The following is a description of a gene set: A large lipoprotein particle (diameter 75-1200 nm) composed of a central core of triglycerides and cholesterol surrounded by a protein-phospholipid coating. The proteins include one molecule of apolipoprotein B-48 and may include a variety of apolipoproteins, including APOAs, APOCs and APOE. Chylomicrons are found in blood or lymph and carry lipids from the intestines into other body tissues. species: Mus musculus Mouse Gene Set: GOCC_CHYLOMICRON, and this is the list of marker genes: Apob (apolipoprotein B), Lsr, Lpl, Apoa5, Apoh, Apoa2, Apoa4, Apoc2, Apobr, Apoc2l, Apoe, Apoc3, Apoa1